Given this list of marker genes TAB3, CLEC6A, CEP162, HTR3A, NAT8L, CARM1, SLC35A4, SRL, PHF20L1, ITGB1BP1, SLC7A6, MAGIX, NEO1 (neogenin 1), SRCAP, CALR, DLD, CPA4, LYPD6, SLC43A3, B4GAT1, DYSF, CSF3R, ESCO1, VWA8, NTNG1, RTKN2, TYRO3, SPTBN4, FGF14, C1GALT1, FMR1, DPP6, CEP152, SH2B3, SMIM8, DLL3, ZHX1, PITPNM2, MSMO1, SLC37A2, CAP1, TMEM51, MECP2, HIP1R, PPP1R1B, PCDH10, SAMD4A, SLC12A5, PHF19, NKAIN3, CDC25B, LHFPL5, STPG1, POF1B, ATP2B4, KCNH5, SERPINB12, FERMT2, SELENOT, DKC1, CALM3, AGPAT3, DNAJC5B, BAG5, PMEPA1, MOSPD2, RTF1, CARNS1, RAI1, FAM222A, SLCO1B1, PRKG1, PRSS12, ILRUN, here is a description of the gene set: Genes predicted to be targets of miRBase v22 microRNA hsa-miR-4650-5p in miRDB v6.0 with MirTarget v4 prediction scores > 80 (high confidence targets). Human Gene Set: MIR4650_5P studied in species Homo sapiens from publication Chen Y, Wang X (PMID 31504780)